Given this list of marker genes ESD, JADE2 (NCBI Gene Id 23338), TRIO, C1orf21, HHAT, AMMECR1, FOLR2, USP30, RHOJ, FARP1, VCL, GPRASP3, TLNRD1, SNRPA1, ANXA3, ADGRG6, STAP1, TMEM71 (NCBI Gene Id 137835), PRKD3, IL21R, PEDS1, RGS18, KRAS, KIF4A, MCOLN3, GAS8, SEMA4C, CHEK1, PDE7B, RAB5B, MAP4K1, TM7SF2, SERTAD2, MRPL45, MTO1, MMP12, GDE1, CD80, CD200R1, DCBLD2, PGK1, RPS6KA2, NOC4L, COQ10A, PRDX2, OSM, KPNA4, SLC28A2, ARHGAP6, FBXO34, WDR37 (WD repeat domain 37), TTC39C, CDKN1A, BRCC3, MRPL35, PLK2, KNOP1, EIF3E, RCN1, COQ10B, MAPK10, SELENOM, ITGB3, MFGE8, SYT11, CHST11, PPP1R16A, PARP16, BMS1, NPRL2, YPEL2, AHCYL2, UNC119B, CD300LD, FOLR1, CST6, SH3PXD2B, EID2, TXNDC5, SQLE, ITGAM, SLC2A1, SUOX, RBM8A, XPR1, RASSF5 (NCBI Gene Id 83593), GOT2, ST3GAL2, KCTD17, PLAU, PDIA3, WTIP, ETV5, BDH2, RARG, SAMSN1, TMEFF1, ERAP1, TTC9C, PRKCB, CD300LF, RASSF8, CD84, GTF2IRD1, PFN2, SLC25A13, HTR2B, KLHDC9, SULT1E1, MGAT2, C3orf70, CX3CR1, NASP, TBL1XR1, CCR5, ERG28, MKI67, MRGPRE, BTG1, CMC2, DTX3, CCNI, EOLA1, PTPRE, TIMP2, DNAJB4, TSPAN5, SOX9, TBC1D22B, RCBTB1, KCNA3, CCNE1, EIF2AK1, CACNA2D1, GUSB, IRX5, CD72, PLP2, CHAF1B, RHOB, YES1, TRNP1, HES3, RGS12, F8A1, AHCYL1, VWF, ARSJ, SH2D3C, RELL2, RNF149, RCHY1, SMAD4, CPT1C, RAB19, NFIX (NCBI Gene Id 4784), PTK2, SH3BP4 (NCBI Gene Id 23677), CRYGN, DDX31, TRAPPC5, ZCCHC24, PXDC1, LIG1, PTPRA, TES, XDH, RCBTB2, PTRH1, BTG3, MYO3A, FAT3, FAM156A, AKT3, HAUS6, CCRL2, BCL2A1, FAM117A (family with sequence similarity 117 member A), AK8, EHHADH, ESPL1, TMEM53, DNAJA1, TSEN34, RAB27B, AFG2B, QPCT, EEIG1, RAP1GAP2, TTC33, TMBIM4, RASAL3, NUP93, PHLDA1, FCGR3A, TMEM154 (NCBI Gene Id 201799), PTGIR, ZRANB3, SC5D, APMAP, here is a description of the gene set: Genes up-regulated in bone marrow-derived macrophage (45 min): LPS versus IL10 and LPS. IL-10 or IL-6 stimulation of control 129xC57BL/6 murine bone marrow derived macrophages in the presence of LPS. We used microarrays to detail the global programme of gene expression changes in response to IL-6 or IL-10 stimulation in the presence of lipopolysaccharide. BMDMs were isolated from control, IL-6-/-, and IL-10-/- mice on a 129XBL/6 mixed background mice and differentiated in the presence of CSF-1 for 6-7 days. Cells were scraped and plated in 6 well plates at 2x10e6/well. Cells were washed with complete DMEM and rested for 1-2 hr before stimulation with combinations of IL-10 (10 ng/ml), IL-6 (2 ng/ml) or LPS (100 ng/ml) for 45 min or 180 mins. Complete biological replicates were performed. studied in species Homo sapiens Human Gene Set: GSE5589_LPS_VS_LPS_AND_IL10_STIM_MACROPHAGE_45MIN_UP from publication El Kasmi KC, Holst J, Coffre M, Mielke L, de Pauw A, Lhocine N, Smith AM, Rutschman R, Kaushal D, Shen Y, Suda T, Donnelly RP, Myers MG Jr, Alexander W, Vignali DA, Watowich SS, Ernst M, Hilton DJ, Murray PJ (PMID 17114459)